The following is a description of a gene set: Genes predicted to be targets of miRBase v22 microRNA hsa-miR-6738-5p in miRDB v6.0 with MirTarget v4 prediction scores > 80 (high confidence targets). Human Gene Set: MIR6738_5P from publication Chen Y, Wang X (PMID 31504780) species: Homo sapiens, and this is the list of marker genes: MKRN1, DISC1, SYP, ST6GALNAC6, VGF, TEX51, RAB5B, CASP14, CASP2, DOCK9, KAAG1, TRIM14, ARHGEF37, IL24, CEP20, FAP, CD1C, BMF (Bcl2 modifying factor), COMMD9, GDE1, DHRSX, ZFYVE28, TRIM11, KIAA1143, KDM5C, GOLM2, IGLON5, NOVA1, KCNQ3 (NCBI Gene Id 3786), FOXP4, DNAI1